The following is a description of a gene set: from publication Longo NS, Lugar PL, Yavuz S, Zhang W, Krijger PH, Russ DE, Jima DD, Dave SS, Grammer AC, Lipsky PE (PMID 19023113) Human Gene Set: GSE12845_IGD_POS_BLOOD_VS_NAIVE_TONSIL_BCELL_DN species: Homo sapiens Genes down-regulated in comparison of IgD+ peripheral blood B cells versus IgD- naive tonsil B cells. B cells from human tonsil and blood were sorted using flow cytometry. The human samples were processed immediately ex-vivo using markers for known B cell subsets., and this is the list of marker genes: PPP1R10, MTA1, NAA16, HMGXB4, HAUS3, CLASP2, H2AX, ARID5A (AT-rich interaction domain 5A), ETHE1, KPNA1, NUSAP1, CIITA, PRC1, NCL, GLA, PLIN3, CSRNP2 (NCBI Gene Id 81566), TMEM260, LPP (LIM domain containing preferred translocation partner in lipoma), EIF2AK3, TUBB, TIPRL, MAFG, MED13L, UAP1L1, ALG13, YPEL5, DNM2, CFAP20, SPRY2, IFNGR1, ADGRE5, UTS2, LY9, FAM120A, BIK, SLC66A2, SIAH2, RASSF2, TNRC6B (trinucleotide repeat containing adaptor 6B), ZNF14, KCNAB2, LMO4, BLNK, ASB13, TRMO, TGIF2, INTS6, FAM30A, NOP2, PELO, CHD1, GRK5, MCM6 (minichromosome maintenance complex component 6), SLC43A3, USP8, SLC38A2, FBXO21, BHLHE40, CD1D, TUBB3, MAT2A, CD55, CALM1, ZNF731P, SLC39A14, KLF9, NGLY1, MAFF, ZNF672, AKR1A1, CKAP2, EIF5, BNIP3L, SFPQ, SCO2, CD19, ZBED2, GSN, NAT10, PPP1R16B, KANSL2, BATF, ZNF253, CD209 (CD209 molecule), NFYA, LNPEP, IL6ST, SPEN (NCBI Gene Id 348488), EZR, DCAF13, AFG2B, LRRK1, IKZF5, PA2G4, INSIG1, BASP1, EGR2, PPIF, FILIP1L, PRKRIP1, VASP, SUPT5H, NET1, LMNB1, EZH2, MYBL2, PGAP1, KLHL18, AMT, SEPTIN6, TPR, ACTG1, EDEM3, SLC38A6, ACSL1, TTC21B, B4GALT5, IKZF1, MTHFD2, AVL9, IRF4, LPCAT1, SBNO1, PUM1, WBP11, GYPC, DNMT3A, TAF1D, MAP3K5, JUN, AKAP13, NR1D2, SH2B3, GRB2, HEG1, ZBTB1 (zinc finger and BTB domain containing 1), WDR74, ZBTB25, RSRC2, CYP51A1, PLK1, SRSF11, IFT46, SPAG4, CABIN1, MOB3B, TUBA1B, MAPK1IP1L, RNF19B, ZC3H15 (zinc finger CCCH-type containing 15), MAD2L1, ILF3, DUSP2, ALDOC, RBM3, CR2, LONP2, LGALS3, FOXO3 (forkhead box O3), PMS2P3, CHL1, SARAF, DUSP3, ZNF10, EIF4G3, SLC12A6, SLC25A13, GALNT1, GAPDH, RIOK2, BCAR3, SYNE1, MRPL52, KIF5B, OTUD4, MAPRE2, SLC23A2, KDM2A, SNAPC1, PDK1, CRTC3, RBM23, GTF2I, ZNF117, DENND1B (DENN domain containing 1B), BTG1, EP300, CLK1 (NCBI Gene Id 1195), RBM48, SRC, CYTH4, SEL1L (SEL1L adaptor subunit of SYVN1 ubiquitin ligase), JARID2, SLC9A8, MARCKSL1, ZNF654 (zinc finger protein 654), MBNL1, DDX47